The following is a description of a gene set: Human Gene Set: GOBP_CEREBELLAR_PURKINJE_CELL_LAYER_FORMATION species: Homo sapiens The process that gives rise to the cerebellar Purkinje cell layer. This process pertains to the initial formation of a structure from unspecified parts. The Purkinje cell layer lies just underneath the molecular layer of the cerebellar cortex. It contains the neuronal cell bodies of the Purkinje cells that are arranged side by side in a single layer. Candelabrum interneurons are vertically oriented between the Purkinje cells. Purkinje neurons are inhibitory and provide the output of the cerebellar cortex through axons that project into the white matter. Extensive dendritic trees from the Purkinje cells extend upward in a single plane into the molecular layer where they synapse with parallel fibers of granule cells., and this is the list of marker genes: CEND1, GBA1, TTLL1, AGTPBP1, HERC1, FAIM2, WHRN, TTC21B, ATP7A, LDB1, LHX1, SKOR2, LHX5, SLC25A46, RORA, FOXP2